The following is a description of a gene set: Enables the transfer of a solute or solutes from one side of a membrane to the other according to the reaction: proline(out) + Na+(out) = proline(in) + Na+(in). species: Mus musculus Mouse Gene Set: GOMF_PROLINE_SODIUM_SYMPORTER_ACTIVITY, and this is the list of marker genes: Slc6a20b, Slc38a2, Slc6a15, Slc6a20a, Slc38a1, Slc6a7